Given this list of marker genes ELOA, GNPTG, PIF1, OIP5, RPL3, TUBB4B, NUDT1, SPC24, PIAS3, NUCKS1, SLC25A39, PCYT1B, WDHD1 (NCBI Gene Id 11169), UHRF1 (NCBI Gene Id 96185), CDC25C, ULK1 (NCBI Gene Id 8408), H3C4, NEIL3, CYP4F3, NHEJ1, SMC4, EIF3H, POLD4, SLC36A2, TPMT, IMPA2, CDCA8, CBX5, ZNF277, EHMT2, PMS2, HASPIN, MCM4, CEP44, PARPBP, ATAD5, TMEM107, AIMP1, WEE1, LRWD1, ERCC6L, KIF20B, PPP2R5D, CCR2, C4orf46, PCNT, EIF3L, IFT80, ANP32E, RIPK3, TEF, NPRL2 (NPR2 like, GATOR1 complex subunit), CEP89, KIF18A, USP3, KIF22, DDT, LSM4, HMGB3, CD109 (CD109 molecule), LANCL2, EEF1G, AHCY, EIF2A, TUBA1A, REEP4, DPP8, TBL1XR1, ARHGAP9, ECT2, GEMIN8, UBE2S, CNPY4, BCAP31, BORA, NELFCD, MLF1, H2AX, PHF5A, EZH2, PLK4, RBM11, TMED4, PLP2, NEURL1B, FOXM1, TOPBP1, SUCLA2, FANCD2, KIF20A, CENPL, DHX40, NTPCR, RFWD3, TTK, HP1BP3, DBP, CIP2A, STIL, ACRBP, HPGD, C1orf21, RAD51AP1, CEP20, HMGN5, ARHGAP11A, POLE, HACD4, SLC39A8, PRIM2, RPN2, POLA1, MAB21L2, CCT4, GRK2, TXNIP, C9orf40, VRK1, SYCE2, FXR1, TNFRSF13B, GINS2, PARD6A, ACADM, OAZ2, CENPP, NDRG3, ATP5F1D, GMNN, SLA (Src like adaptor), CEP55, ATAD2, FBXL8, CDK19, CEP128, TRMT2B, ZNF106, B9D2, STK35, MDH1, GID4, CDC45 (NCBI Gene Id 8319), VKORC1, STING1, HNRNPA1, PAICS, CENPU, MELK, MIS18A, NCBP3, NRM, SLC9A6, CCNE2, TERF1, LMNB2, TEDC1, SIAE, PABIR2, STK38, CEP95, MSTO1, TRIM59, CENPE, KMT5C, CD2BP2, CEP83, GTSE1, ZFAND4, TTC9C, PBX3, SERPINI1, NCAPD2, ATL2, NTAQ1, NUP155, G2E3, LCMT1, CENPT (centromere protein T), ERGIC3, CDKN2D (NCBI Gene Id 1032), TSGA10, ZNF467, SURF1, KNL1, LRRC40, MPHOSPH9, SUV39H1, NCAPH, NUP107, DESI2, MR1, RPA2, SPN, CENPO, EBP, WARS2 (tryptophanyl tRNA synthetase 2, mitochondrial), IDH3G, CHEK1, DHRS7B, UEVLD, here is a description of the gene set: Human Gene Set: GSE25085_FETAL_LIVER_VS_ADULT_BM_SP4_THYMIC_IMPLANT_DN Genes down-regulated in thymic implants from fetal liver versus those from adult bone marrow. species: Homo sapiens from publication Mold JE, Venkatasubrahmanyam S, Burt TD, Michaëlsson J, Rivera JM, Galkina SA, Weinberg K, Stoddart CA, McCune JM (PMID 21164017) Human fetal and adult hematopoietic stem cells (HSC) were obtained from fetal liver, fetal bone marrow (BM), and adult BM. These were injected into human fetal thymic implants in SCID-hu Thy/Liv mice (4-6 separate mice per HSC donor) and allowed to mature into single positive CD4+ (SP4) thymocytes over the course of 7-8 weeks. SP4 thymocytes from injected stem cells were subsequently sort-purified from thymic implants and gene expression was performed.